The following is a description of a gene set: Cytokines mediate cell-cell communication in the immune system and represent important therapeutic targets. A myriad of studies have highlighted their central role in immune function, yet we lack a global view of the cellular responses of each immune cell type to each cytokine. To address this gap, the authors created the Immune Dictionary, a compendium of single-cell transcriptomic profiles of more than 17 immune cell types in response to each of 86 cytokines (>1,400 cytokine-cell type combinations) in mouse lymph nodes in vivo. A cytokine-centric view of the dictionary revealed that most cytokines induce highly cell-type-specific responses. For example, the inflammatory cytokine interleukin-1β induces distinct gene programmes in almost every cell type. A cell-type-centric view of the dictionary identified more than 66 cytokine-driven cellular polarization states across immune cell types, including previously uncharacterized states such as an interleukin-18-induced polyfunctional natural killer cell state. from publication Cui A, Huang T, Li S, Ma A, Pérez JL, Sander C, Keskin DB, Wu CJ, Fraenkel E, Hacohen N (PMID 38057668) species: Mus musculus Genes positively differentially expressed in cell type: Monocyte upon treatment with cytokine: TNF-α in mouse lymph nodes in vivo. Mouse Gene Set: CUI_MONOCYTE_TNFA_RESPONSE_UP, and this is the list of marker genes: Cebpb, Lcp1, Plaur, Ak2, Stxbp3, Sod2, Id2, BC031181, Bnip2, Sdc4, Gmfg, Nab2, Spred1, Sh3bp1 (SH3-domain binding protein 1), Nfkbia, Csf2rb2, Clec4e, Lpcat2, Sumo2, Cd14, Upp1, Mcemp1, Mllt6, Ctsz, Dusp2, Appl1, Bcl2a1a, Pfn1, Ptprj (NCBI Gene Id 98976), Rhbdf2, Rab32, Hp, Mtdh, Grk3, Treml4, Slc7a11 (solute carrier family 7 (cationic amino acid transporter, y+ system), member 11), Mrpl52, Psme2, Stimate (STIM activating enhancer), Acod1 (NCBI Gene Id 16365), Saa3, Fkbp5, Sirpa, Cdc42ep2, Zmiz1, Sav1, Cd44, C5ar1, Hnrnpa3, N4bp1, Clic4, Serpinb8, Ms4a6d, Orai2, Hif1a, Nlrp3, Atp6v1c1, Cers6, Socs3, Clec5a, Marcksl1, Adam17 (a disintegrin and metallopeptidase domain 17), Snx3, Trem1, F10, Ezr, Clec4n, Runx3, Fhod1, Tnfaip3, Sh3bgrl, Ptges, Foxp4, Clec4d (NCBI Gene Id 17474), Dusp16, Eif4g2, Vasp (NCBI Gene Id 22323), Ppp4r2, Pebp1, Gsap, Mapkapk2, Man2a1, Traf1, Fth1, Ccdc50 (coiled-coil domain containing 50), Msn, Camta2, Gpr84, Tank, Trem3, Calm1, Hcls1, Dram1, Acp2, Bcl2a1b, Msr1, Srsf2, Cxcl16, Ralgds, Il4i1, Ass1, Myl12a, Psmd10, Cd82, Nr1h3, Lacc1, Fgr, Ankrd13c, Cmklr1, Adgre4, Lcp2, Cox17, Nfkb2, Kmt5a, Arl5a, Hck, Cggbp1, Rgl1, Tnf (tumor necrosis factor), Ciao2b, Ccdc88b, Srgn, Slpi, Med11, Prdx5, Wapl, Pdia6, Ift57, Prkd3, Smarca5, Snx18, Ggh, Gda, Ninj1, App, Tmem214, Plpp1, Nrp2, Fpr1, Ikbke, Bcl2a1d, Ptk2b, Bhlhe40, Pid1, Ggct, Smpdl3b, Tbc1d2b, Pilra, Ifi205, Ehd1, Prkcd, Cd38, Fpr2, Efhd2, Mtm1 (NCBI Gene Id 56614), Malt1, Avpi1, M6pr, Plek, Aebp2, Fcer1g, AA467197, Csf2rb (NCBI Gene Id 12983), Icam1 (intercellular adhesion molecule 1), St3gal1, Ppp1r14b, Rnf149, Ptafr, Ybx1, Fnbp1l, Tnip1, Nfe2l2, Calr, Cybb, Vamp8, Il1rn, Slc16a10, Rasgrp1, Pla2g7, Sema4d, Rab20, Rrad, Cd274, Tgm2, Mmp14, Abracl, Ldha